Given this list of marker genes Naa40, Kat8, Taf9, Nap1l2, Kat6b, Usp22, Brpf3, Msx3, Mcm3ap, Nat8f3, Ncoa3, Clock, Esco2, Kat5, Naa60, Kat6a, Gtf3c4, Nat8f7, Ep300, Ing4, Kat14, Meaf6, Brca2, Nat9, Brd1, Atat1, Taf10, Gtf2b, Naa30, Naa20, Med24, Naa50, Tada2a, Crebbp, Taf1 (NCBI Gene Id 270627), Phf10, Mettl8, Atf2, Hat1, Ncoa1, Oga, Esco1, Pygo2, Naa12, Naa80, Kat7, Abhd14b, Ing3, Brpf1, Kat2a, Bloc1s1, Kat2b, Naa10, Cdyl, Naa11, Jade1, Jade2, here is a description of the gene set: studied in species Mus musculus Catalysis of the acetylation of an amino acid residue of a peptide or protein, according to the reaction: acetyl-CoA + peptide = CoA + N-acetylpeptide. Mouse Gene Set: GOMF_PROTEIN_N_ACETYLTRANSFERASE_ACTIVITY